The following is a description of a gene set: Human Gene Set: GSE20727_CTRL_VS_ROS_INH_AND_DNFB_ALLERGEN_TREATED_DC_UP Genes up-regulated in dendritic cells: control versus 2,4-dinitrofluorobenzene (DNFB) and diphenyleneiodonium (DPI). from publication Miyazawa M, Takashima A (PMID 22974541) Identification of ROS induced genes on dendritic cells Dendritic cells were incubated for 15 min with or without a ROS inhibitor (DPI), washed extensively and incubated for 30 min with a chemical allergen (DNFB), hydrogen peroxide, and vehicle alone in HBSS containing DPI or vehicle. After washed extensively, the samples were post-incubated for 5.5 h with DNFB, hydrogen peroxide, or vehicle in complete culture medium containing DPI or vehicle. studied in species Homo sapiens, and this is the list of marker genes: LRRK2, SH3PXD2A, ZFAS1, TAGLN2, ACTR1B, DNAJC30, SKP2, BAIAP2-DT, ITFG2, TMEM205, TST, RNF26, FAM162A, CD58, HEATR6, NLRX1, XPC, HACD4, TBC1D4, TNK2, SCPEP1, NQO1, METTL9, JADE2, NEK9, NUDT6, PABPC1, CSTA (NCBI Gene Id 378889), SOWAHC, BACE1, NPIPA1, OARD1, BANF1, PIGS, SH3BGRL3, G6PC3, LHPP, REPIN1, PSTPIP2, TEF, LONP1, BBLN, RPTOR, LZTFL1, ACP6, ANP32A, HACL1, DPCD, KCNAB2, ZMYM3, MRPL57, CSDE1, PTGES2, HK2, TXNIP, COX5B, MCAM, ACO1, U2SURP, EPRS1, COX4I1, PHF10, VRK1, OTULINL, SLC27A3, POGLUT1, CYB561A3, EPHX1, LGALS2, HMGN3, RBM43, NACA, IKBKE (NCBI Gene Id 9641), IVD, MRPS34, BTD, BCKDHA, KCTD3, GPAT3, ATG7, OLIG1, NAA80, CLEC12B, HVCN1, LINC01138, ZBTB3, FN1, MRPS24, MRI1, HCST, POLR1H, AKAP1, CSTF3 (NCBI Gene Id 1479), TMEM218, NONO, ZNF74, NDC1, NCF1C (neutrophil cytosolic factor 1C (pseudogene)), ECHDC1, COG2, B3GNT2, SETD6, ECI1, TNFAIP2, ADISSP, OAF, GNA12, KIF20B, TMEM14C, FAM78A, RPS27 (NCBI Gene Id 6232), ATRAID, SF3A3, ACVR2A, TCEAL8, RAD51C, EHMT2, GTF3C2, CCDC88C, RCC2, PNPO (NCBI Gene Id 55163), ZFAND1, SUPV3L1, THAP11, STN1, COQ9, UBXN11, ZFP64, CD101, CEP120, IL13RA1, CEP85, ARSG, NCAPD2, TMEM138, NCOA7, CCL4, IL11RA, MCEE, KLHL8, PSAP, HDGF, CDK10, FNBP4, MGST1, C11orf21, FBXL5, ATP6V1A, IFT172, TYSND1, PRCP, KLF13, RPS6KA5, ADA2, UQCRC2, PTGFRN, PID1, SPCS1, TADA1, PPARGC1B, MAN2B1, ITGB2-AS1, EPB41L4A-AS1, COQ8A, PTPRE, ATP6V1F, SLC16A6, WAC, GPX4 (NCBI Gene Id 2879), TFDP2, ARHGAP22, TECR, LFNG, SARS2, JUP, MYCBP2, SCP2, PCBP2, CDRT4, PDIK1L, RSAD1, PBX3, POLRMT, MARCKSL1, CLEC11A, SEMA4D, SLC25A40, DIAPH2, ECH1, CHCHD10, OPN3, DGLUCY, NIN, RCSD1, MRPL40, NDUFS3, SLC9A3-OT1